The following is a description of a gene set: Human Gene Set: REACTOME_METABOLISM_OF_LIPIDS Metabolism of lipids studied in species Homo sapiens, and this is the list of marker genes: AKR1C4, PEMT, SEC24D, PPARA, GLB1, FDX2, PTPMT1, TBL1X (NCBI Gene Id 6907), ACOT8, ACP6, ARSK, OSBPL2, ME1, DECR1, ELOVL3, MED16, PI4K2B, LPIN3, MED19, PRKAB2, SPTLC3, SPHK1, ACOT7, DEGS1, GRHL1, CAV1 (caveolin 1), SLC51A (NCBI Gene Id 200931), PIP5K1A, HSD11B2, MMAA, PPM1L, GPD1L, PRKAA2, GPX2, PIKFYVE, MBTPS1, TAFAZZIN, PLA2G4D, AGPAT5, PLD6, LDLRAP1, CYP2U1, SLCO1B3, SBF1, GLB1L2, RXRB, HPGDS, ACAD10, CDS2, LCLAT1, LIPH, ABCB4, GGPS1, ALOX12, LBR, OSBPL3, CYP17A1, MED20, CYP7A1, HADH, DHCR7, SLC27A1, CPT1B, PIK3R4, LPIN1, MED14 (mediator complex subunit 14), STARD4, AACS, RXRA, SLC44A1, ACOT11, LPIN2, HEXA, SYNJ2, FABP5, NR1H2, FDX1, ORMDL2, PLEKHA2, PNPLA7, SGPL1, AHR, PLD2, MIGA2, TGS1, MED4, FABP6, ACHE, CCNC, HELZ2, ALOX5, CERS3, ACOT9, SRD5A1, MOGAT2, NCOA3, ACSL6 (NCBI Gene Id 56972), PI4KB, LPCAT1, ORMDL1, CYP4A11 (cytochrome P450 family 4 subfamily A member 11), TNFAIP8L2, ELOVL6, INPP5K, SPTLC2, HSD17B12, INPP5D, SULT2A1, MIGA1, DHCR24, CYP2C19, NFYC, PLA2R1, RAB14, ALOX5AP, PLPP6, BMX, TM7SF2, CERT1, SPHK2, PTGES2, MFSD2A, ABHD4, PLA2G5, ENPP7 (NCBI Gene Id 339221), ACADL, HSD17B8, MBOAT2 (membrane bound O-acyltransferase domain containing 2), UBE2I, OSBPL6, TBXAS1, ARSF, FABP4, ASAH2, CSNK2A2, SREBF2, GDPD3, PRKACA, SIN3B, VAPB, TPTE2, PTGS2, PLAAT2, ACAT1, ACBD6, HACD4, CYP11B2, CSNK2B, PNPLA3, RORA, HMGCS1, ABCG2, CPNE3, LTA4H, GGT1 (NCBI Gene Id 91347), SPTSSB, SGPP2, ACBD4, CREBBP, GK, GGT5, HEXB, ACBD7, GPAT3, ELOVL5, CYP11A1, NCOR2, FIG4, NFYB, MMUT, FUT2, UGT8, PPARGC1A, PLAAT1, SEC24C, GPAM, ACER3, SPTLC1, MED31, GM2A, MED30, GK2, ORMDL3, ACOX1, AWAT2, CERS4, SRD5A2, ARSD, TPTE, FHL2, FASN, FA2H, INPPL1, LTC4S, STARD3NL, TRIB3, CYP2R1, ARF1, GPD1, CBR4, MED7, EHHADH, PITPNM2, SCD, CTSA, PTDSS1, AGK, PCYT2, CRLS1, CYP39A1, PRKACG, ASAH1, PNPLA8, ARNT2, ACER2, MED24, MED6, ALOX15, SLCO1A2, ST3GAL3, SMPD1, ACSF2, HILPDA, SLC22A5, MED26, NUDT19, MED13L, PHYH, ACOT13, PECR, PLA2G12A, NRF1, IDI1, AKR1C2, CYP4B1, MCAT, TNFAIP8L1, FABP3, TIAM2, GDPD5, MED9, CDK8, OLAH, BDH1, PLA2G4A, CYP51A1, CPNE6, OSBPL7, AGPAT3, HMGCS2, GALC, PIK3C3, FABP7, PRKD2, PTGR1, CYB5B, PLA2G2D, NEU3, ESRRA, B3GALNT1, MED11, GC, SEC23A, DDHD2 (DDHD domain containing 2), ALDH3B1, LIPI, LPCAT2, NR1H3, SEC24B, NR1D1, ARSJ, ALPI, DPEP2, ACOT4, BMAL1, ST3GAL2, SLC44A3, MTMR8, CYP4F3, ACADM (NCBI Gene Id 51779), APOA1, STAR, NEU2, PLA2G2F, MOGAT1, FABP12, ABCD1, PIK3CB, MED22, SELENOI, SLC25A20, CERS2, UGCG, PIK3C2G, SCD5, CERS5, AGPS, LPCAT3, SLC44A4, CIDEA, HDAC3, PLEKHA6 (pleckstrin homology domain containing A6), MFSD2B, MTMR4, MED29, PLD4, PIP5K1C, CYP4A22, AKR1B1, SUMO2, ARF3, MLYCD, RAB4A, HSD3B2 (hydroxy-delta-5-steroid dehydrogenase, 3 beta- and steroid delta-isomerase 2), NEU1, APOA2, HSD17B14, FADS2, INPP5E, STARD6, SLC10A1, PIP4K2A, GLA, HACD2, PIK3CD, INPP5F, SLC51B, GPCPD1, ACOXL, FAR2, ACSF3, ACLY, MTMR2, CYP1A1, TSPOAP1, CYP27A1, NUDT7, ELOVL7, MED21, MED28, PCCB, STARD10, LIPE, PNPLA5, FDFT1, PPT2, ACSS3 (acyl-CoA synthetase short chain family member 3), B3GALT4, CYP2E1, PON2, PIP5K1B, ECI2, POMC, CYP4F11, GAL3ST1, TECRL, CYP2C8, PLD3, INPP4B, PLEKHA5, HACD3, ACSM3, DHRS7B, FABP1, THEM4, EPHX2, ABCB11, INSIG1, ACOT1, IDI2, CH25H, ACSL4, ETNPPL, PLPP1, PGS1, ALDH3B2 (aldehyde dehydrogenase 3 family member B2), GSTM4 (glutathione S-transferase mu 4), SGMS1, HMGCL, PIK3C2A, B3GNT5, ACSBG1, PIK3C2B, PTGS1, MED8, PCCA, ACAT2, PLA2G2E, PCTP, PCYT1B, PLA2G6, NCOR1, SEC24A, CYP8B1, PITPNB, PLA2G4C, PLEKHA1, PIP4P1, CHPT1, PITPNM3, KDSR, ABCC3, TSPO, STS, HSD17B13, MTMR3, ACSM6, MTMR1, GDPD1, ALOX12B, APOA5, MCEE, ELOVL1, SUMF1, CYP11B1, CIDEC, MTMR14, MED25, CYP24A1, MID1IP1, ANKRD1, PMVK, CHKA, RGL1, PLA2G3, ACADS (acyl-CoA dehydrogenase short chain), CERK, AKR1D1, ENPP6, PLAAT5, HMGCR, RAB5A, GNPAT, PLEKHA4, ALDH3A2, CERS1, A4GALT, FAAH2 (NCBI Gene Id 158584), MED1, INPP4A, NCOA6, PTGR2 (NCBI Gene Id 145482), KPNB1, DEGS2, MORC2, SLC27A5, PPP1CA, SC5D, FADS1, ELOVL4, GLB1L, PRKAG2, HACL1, HSD3B7, THRAP3, CHAT, MVD, PNPLA2, PLA2G4F, DGAT2L6, FAAH, INPP5J, CYP1B1, MTMR6, MED18, HADHB, CYP27B1, FAM120B, OSBPL10, CD36, OSBP, THRSP, PIK3R2, MED13, PLD1, MOGAT3, ETNK2, ST6GALNAC5, PLAAT4, CHD9, PNPLA6, MED23, TNFAIP8L3, GPAT4, ACACA, MECR, SREBF1, DBI, ACAA1, PIK3R6, ALOX15B, FAR1, CYP2J2, NFYA, B4GALT5 (NCBI Gene Id 9334), SMPD4, PTPN13, PPARD, GK3, HAO2, PLAAT3, NDUFAB1, AKR1C3, BCHE, PLA2G4B, FDPS, MBOAT1, TNFRSF21, VAC14, PIK3R1, PIAS4, ST6GALNAC6, ARV1, MTM1, PIK3CA, HSD17B3 (hydroxysteroid 17-beta dehydrogenase 3), DECR2 (2,4-dienoyl-CoA reductase 2), SQLE, TXNRD1, PIK3R3 (phosphoinositide-3-kinase regulatory subunit 3), SRD5A3, PLEKHA8, MTF1, ACER1, SLC27A2, ACAD11, HSD17B1, OXCT2, ACSL1, PTGDS, SGPP1, PLA2G1B, CSNK1G2, SLCO1B1, GPAT2, DGAT2, PLA2G10, CDIPT, ALAS1, STARD7, SLC44A5, FABP2, AMACR, GPX1 (NCBI Gene Id 2876), M6PR, HSD3B1, GPX4, LGMN, CDS1, VAPA, HSD17B11, SMPD2, PI4K2A, TMEM86B, BAAT, ARSG, ACSBG2, PRXL2B, PPARGC1B, OSBPL5, MED17, PPP1CC, HSD11B1, G0S2, PHOSPHO1, ARSI, CYP4F2, CROT, ST8SIA5 (ST8 alpha-N-acetyl-neuraminide alpha-2,8-sialyltransferase 5), DGAT1, ANGPTL4, ARSL, ACACB (NCBI Gene Id 32), PISD, PI4KA, LRP2, PLA2G2A, SCP2, PRKD1, GPS2, PIK3R5, RUFY1, NCOA1, ABHD3, CYP7B1, CYP1A2, CUBN, OSBPL1A, FITM1, B4GALNT1, CYP2D6, PLPP2, CPNE1, PTGES3, GPD2, PLPP3, SLC27A3, PON1, AGPAT2, ECHS1, GLIPR1, TNFAIP8, PLA2G15, AGPAT4, STARD3, SLC25A17, SIN3A, PRKACB, ABCA1, OCRL, OSBPL8, SUMF2, SERPINA6, STARD5, RAN, CGA, HSD17B2, HPGD, LPGAT1, SACM1L, LSS, ACBD5, PTGES, HSD17B7, CEPT1, AWAT1, ARSA, FDXR, SMPD3, AGPAT1, ABHD5, MBTPS2, GDE1, ARSH, TBL1XR1, PNPLA4, NEU4, CARM1, CYP4F8, LHB, ACSL3, CYP3A4, GLB1L3, AGT, GBA3, PTEN, AKR1B15, SLC44A2, CBR1, ACADVL, ALOXE3, PON3, CYP4F22, PPT1, CDK19 (cyclin dependent kinase 19), PPARG, DPEP1, MED10, PTDSS2, CYP21A2, SP1, LPCAT4, NCOA2, HADHA, HMGCLL1, PEX11A, GBA1, NSDHL, NPAS2, PPP1CB (NCBI Gene Id 5500), PLA1A, PLB1, PRKD3, OXCT1, MSMO1, ARNT, FABP9, B4GALT6, HSD17B4, THEM5, MGLL, SMARCD3, MTMR12, EBP, PIP4K2C, MED12, CYP19A1, BDH2, ECI1, SLC10A2, MBOAT7, OSBPL9, MTMR9, PIP4K2B, PIK3CG, ACSL5, ABCC1, SAMD8, PTGIS, ACOT12, PLBD1, ST3GAL5, CSNK2A1, PLIN1, AGMO, GBA2, CYP2C9, MED27, SAR1B, ELOVL2, DDHD1, MAPKAPK2, CPT1A, PLEKHA3, CRAT, ACOT2, CLOCK, AKR1C1, ETNK1, MED15, UGT1A9, PSAP, ARSB, INSIG2, SCAP, CERS6, PCYT1A, CPT2, PLIN2, SPTSSA, HACD1, HTD2, SBF2, ALB, EP300, CYP46A1, CHKB, PGP, PLA2G4E, FITM2, CPNE7, ACOX3, NR1H4, SPNS2, MTMR10, MTMR7, FUT1, ACOX2, PLIN3, TECR, SYNJ1, MVK, ACAA2, VDR, PITPNM1, SGMS2